The following is a description of a gene set: studied in species Mus musculus Mouse Gene Set: GOBP_GLIAL_CELL_DIFFERENTIATION The process in which a relatively unspecialized cell acquires the specialized features of a glial cell., and this is the list of marker genes: Prdm8, Dag1, Arhgef10, Eif2b3, Ilk, Eed, Enpp2, Smarca4, Ano1, Ntrk2, Pals1, Mal, Hdac11, B4galt5, Hmga2, Prmt5, Emx1, Mios, Trp73, Fgfr3, Kras, Cntnap1, Nab2, Tspan2, Sod1, Clu, Ccdc39, Slc45a3, Arsg, Nr1d1, Lin28a, Ncmap, Ptpn11, Sox5, Gfap, Tgfb1, Dlx2, Cul4b (cullin 4B), Serpine2, Pi4ka (NCBI Gene Id 224020), Myd88, Plec, Pten, Pparg, Ror2, Nsun5, Ctnnb1, Dusp15, Rela, Metrn, Mag, Mapk3, Eif2b4, Cxcr4, Dicer1, Atf5, Ror1, Mxra8, Ndp, Wdr1, Drd1, Gli3, Ptpra, Lef1, Mettl3, Mtor, Dlx1, Suz12, Dmd, Cnp, Slc8a3, Pmp22, Vps13a, Sos1, Large1, Mir219a-2, Ckap5, Cntn2, Reln, Abcc1, Ptprz1, Clcf1, Il1b, Gstp1, Itgam, Pick1, Epha4, Eif2b5, Hes1, Id2, Abl2, Pou3f2, Mir23a, Dab1, Csk, Ercc2, Fgf10, Dhh, Mapk1, Kcnj10, Phgdh, Mbd1, Lgi4, Rheb, Enpp1, Olig2 (oligodendrocyte transcription factor 2), Prpf19 (pre-mRNA processing factor 19), Fgf5, Tuba1a, Akt2, Vax1, Sox11, Raf1, Lrp6, Tnfrsf1b, Ptn, Nrg1, Ldlr, Sirt2, Clcn2, Il33, App, Lif, Plp1 (NCBI Gene Id 18823), Neurod4, Tcf7l2, Plpp3, Miat, Kdm4a, Cntnap2, Gsx2, Nf1, Phox2b, Nr3c1, Eif2b2, Akt1, Eif2b1 (NCBI Gene Id 52255), Nkx6-2, Sox13, Gpc1, Gpr17, Egr2, Abl1, Nkx2-1 (NCBI Gene Id 21869), Ndrg1, Naglu, Vtn, Ski, Gm5849, Lpar1, Bag1, Nfe2l1, Ager, Cdh2, Lamb2, Hdac1, Prx, Crb1, Zeb2, Pard3, Ptprj, F2, Opalin, Hras, Spint1, Mobp, Lama2, Bmp4, Mfsd8, Mettl14, Mir219a-1, Pax6, Grn, Nlgn3, Mdk, Adam22, Exoc4, Gpr157, Zfp488, Omg, Abca2, Otx2, B4galt6, Pou3f1 (NCBI Gene Id 18991), Aspa, Myrf, Afdn, Bnip3, Tppp, Notch1, Actr3, Ntf3, Map2k1, Ttc21b, Nfib, Erbb3, Ntrk3, Sox1, Rnf112, C5ar1, Daam2, Nrros, Ccdc85c, Ifngr1, Gpr37l1, Vps54, Lyn, Fa2h, Eomes, Sox6, Bmp2, Cdk5, Lrp1, Gba1, Sox8, Trem2, Sh3tc2, Zfp365, Psen1, Mecp2, Nog, Dll1 (delta like canonical Notch ligand 1), Wasf3, Dner, Shh, Sox10, Dtx1, Cntf, Gcm1, Myoc, Grk2, Cspg5, Egfr, Casz1, Nfix, Trpc4 (transient receptor potential cation channel, subfamily C, member 4), Tlr2, Ncstn, S100a8, Fgf2, Vim, Agt, Nab1, Mycn, Tal1, Lingo1, Adora2a, Ppp3r1, Igf1, Olig1 (oligodendrocyte transcription factor 1), Rtn4, Pfkfb3 (NCBI Gene Id 269236), Sox9, Tenm4, Dll3, 9630013A20Rik, Gpm6b, Erbb2, Col6a1, Bok (BCL2-related ovarian killer), Nkx2-2, Nr2e1, Sox4, Fkrp, Ifng, Ascl1, Rhoa, Drd3, Tlr4, C1qa, Tnfrsf21, Adgrg6, Bin1, Mmp24, Il6st, Nkx6-1, Nfia, Smo, Pax2, Med12, Dusp10, Lamc3, Il34, Grb2, Csf1r, Cdkn2c, Cntn1, Id4, Ulk4, Hdac2, Itgb4, Tmem98, Pdgfb, Hes5 (hes family bHLH transcription factor 5), Slc25a46, Gap43, Map2k2, Dlg5, Qki, Klf15, S100a9, Nkx2-2os, Stat3